The following is a description of a gene set: Genes down-regulated in epithelial cells (24h): untreated versus interferon alpha. Human Gene Set: GSE5542_UNTREATED_VS_IFNA_TREATED_EPITHELIAL_CELLS_24H_DN studied in species Homo sapiens from publication Sanda C, Weitzel P, Tsukahara T, Schaley J, Edenberg HJ, Stephens MA, McClintick JN, Blatt LM, Li L, Brodsky L, Taylor MW (PMID 16800785) Type I and type II interferons (IFNs) bind to different cell surface receptors but activate overlapping signal transduction pathways. We examined the effects of a type I IFN (IFN-acon1) and a type II iFN (IFN-g1b) on gene experession in A549 cells and demonstrate that there is a common set of genes modulated by both IFNs as well as a set of gene specifically regulated by each, reflecting the activation of different signaling pathways. In particualr, IFN-g induced many more genes of the signaling pathways, apoptosis, and cytokine interactions than did IFN-a. Even with genes induced by both IFNs there were distinctive quantitativive differences in expression. IFN-g1b plays a major role in the induction and regulation of the complement pathway. Previous work has shown a synergistic antivral and antiproliferative effect of type I and type II IFNs in cell culture and in the treament of tumors in mice. We demonstrate that a majority of genes showed and additive effect of IFN-acon1 and IFN-g1b, but a subset of gene is synergistically induced; these incluce ISG10, MX2, OAS2, and other genes known to be involved in the antiviral response, TRAIL (TNFSF10) and caspases involved in apoptosis and chemokine genes RANTES, CXCL10, and CXCL11. Greater than additive transcription of some of these genes in the presence of both IFNs was confirmed by real-time kinetic RT-PCR. Elevated induction of many of these genes may be sufficient to explain the synergistic antiviral and antitumor effects of this combination of IFNS in vivo., and this is the list of marker genes: TSPAN32, KCNMB4, TRMT2B, NAT10, MAL, KLHL3, EPHX2, FARSB, FAM117B, NOL11, KCNQ1 (potassium voltage-gated channel subfamily Q member 1), GRAP, SELP, GCA, FNIP2, COX6C, TGFBR2, ZNF391, PPP1R2P1, ZFAND1, RPL23A, SPPL2B, CHML, MAML2, ANKZF1, BEX3, BZW2, RMDN2 (regulator of microtubule dynamics 2), RASSF3, GLB1L3, PPFIBP2, ANGEL1, PIM2, KLF3-AS1, AK3, SUCLG2P2, BTF3, PTPN6, PTK2, WDR73, ANP32B (NCBI Gene Id 138551), GTPBP3, NOM1, CASP10, CYP2B6, ACBD4, TESPA1, FHIT, SLC7A8, PIGK, SH3RF3, DENND2D, MATCAP2, RSL24D1, ACKR3, ADPRM, PRDM5, HMGN3 (high mobility group nucleosomal binding domain 3), PAQR8, DPH6, DPH5, N6AMT1, USP51, NUDCD3, CDNF, MRPL32, PAICS, EIF3E (eukaryotic translation initiation factor 3 subunit E), MTRFR, UBASH3A, KIAA1586, ZNF766, CHCHD7, DENND11, CFAP418, KRT73, IL6R, ALDH3A2, FGGY, GIMAP2, ZNF84, MTHFD1, CEP41, TSEN2, METAP2, SLC40A1, TEX9, MRRF, KCNN4, PCYOX1L (prenylcysteine oxidase 1 like), MINDY1, SNORD114-6, RASA3, MORC2 (MORC family CW-type zinc finger 2), ZNF706, ALPK1, MRPS27, TRABD2A, SCAND2P, MEF2A, RABL3, C1orf162, ARMCX1, AFF2, ST13P5, LINC00174, SFXN1, SAYSD1, TNFRSF10D, LDLRAP1, GLUD1, EDAR, UBTF, TOP1MT, PFAS, ABRAXAS1, CDH23, CRTC3, LYRM4, QTRT1, FAM120B, RABEPK, CEP68, RANBP3, E2F5, PTMA, DCK, RASGRP2, FUNDC2, SLC25A37, ZNF726, AP1M1, HBS1L, OTUD6B, CD79A, RSBN1, STK26, CAD, PTPRK, SCCPDH, CACHD1, ZNF740, DGKA, LMLN, GATM, SMG9, C1QBP, EFCAB13, MIR136, SMAP2, CSGALNACT1, SGTB, ELK4, CDCA7L, ZNF780B, POLL, TMEM39B, FAM229B, ZNF397, MMP28 (matrix metallopeptidase 28), SEH1L, PUM1, ITPKB, XPO6 (exportin 6), USP53, MAX, FMO4, PRKAR1B, EARS2, MPHOSPH8, CHMP7, NOG, GABBR1, RPL14, REXO4 (REX4 homolog, 3'-5' exonuclease), TECPR1, LMO7 (NCBI Gene Id 4008), AIF1, TPST1, KRT72, CBY1, ARRB1, ETFRF1, NUP43, FAM86DP (family with sequence similarity 86 member D, pseudogene), CATSPER2P1, MTA3, COX4I1, CFP, EEF2K, TCEA3, ZNF300, TBRG4, RPIA, MYOM1, NUMA1, CCDC102B